Given this list of marker genes NAMPT, HINT1, HBA2, HSPB1, GDF9, DDX5, RAB1A, TFAP2B, TSPAN8, PLAGL1, DCTN1 (dynactin subunit 1), CKMT2, ARF5, BUB3, SOX17, ATF3, ARHGDIB, ZFP90, STARD7, U2AF2, TGIF1, SMARCC2, MFAP5, RHOB, POU3F2, KRTAP5-2, FOS, GADD45A, NTF3, RAB21, AMY2B, HTRA1, AP3S2, TGFB1I1, HSPA8, CDC42 (NCBI Gene Id 998), ALDH1A1, ACTR1B, here is a description of the gene set: Upregulated in the gastrocnemius muscle of aged adult mice (30-month) vs young adult (5-month) Human Gene Set: LEE_AGING_MUSCLE_UP from publication Lee CK, Klopp RG, Weindruch R, Prolla TA (PMID 10464095) The gene expression profile of the aging process was analyzed in skeletal muscle of mice. Use of high-density oligonucleotide arrays representing genes revealed that aging resulted in a differential gene expression pattern indicative of a marked stress response and lower expression of metabolic and biosynthetic genes. Most alterations were either completely or partially prevented by caloric restriction, the only intervention known to retard aging in mammals. Transcriptional patterns of calorie-restricted animals suggest that caloric restriction retards the aging process by causing a metabolic shift toward increased protein turnover and decreased macromolecular damage. studied in species Mus musculus